Given this list of marker genes Ciao2b, Ercc2, Mms19, Slc25a5, Ciao1, here is a description of the gene set: studied in species Mus musculus A protein complex that contains the proteins MMS19, MIP18 and XPD, localizes to mitotic spindle during mitosis, and is required for proper chromosome segregation. Mouse Gene Set: GOCC_MMXD_COMPLEX